The following is a description of a gene set: Human Gene Set: WU_HBX_TARGETS_2_UP studied in species Homo sapiens Genes up-regulated by expression of HBV X protein (HBVgp3) in primary hepatocytes. from publication Wu CG, Salvay DM, Forgues M, Valerie K, Farnsworth J, Markin RS, Wang XW (PMID 11439330) Hepatitis B virus (HBV) is a major risk factor for the development of hepatocellular carcinoma (HCC). HBV encodes the potentially oncogenic HBx protein, which mainly functions as a transcriptional co-activator involving in multiple gene deregulations. However, mechanisms underlying HBx-mediated oncogenicity remain unclear. To determine the role(s) of HBx in the early genesis of HCC, we utilized the NCI Oncochip microarray that contains 2208 human cDNA clones to examine the gene expression profiles in either freshly isolated normal primary adult human hepatocytes (Hhep) or an HCC cell line (SK-Hep-1) ecotopically expressing HBx via an adenoviral system. The gene expression profiles also were determined in liver samples from HBV-infected chronic active hepatitis patients when compared with normal liver samples. The microarray results were validated through Northern blot analysis of the expression of selected genes. Using reciprocally labeling hybridizations, scatterplot analysis of gene expression ratios in human primary hepatocytes expressing HBx demonstrates that microarrays are highly reproducible. The comparison of gene expression profiles between HBx-expressing primary hepatocytes and HBV-infected liver samples shows a consistent alteration of many cellular genes including a subset of oncogenes (such as c-myc and c-myb) and tumor suppressor genes (such as APC, p53, WAF1 and WT1). Furthermore, clustering algorithm analysis showed distinctive gene expression profiles in Hhep and SK-Hep-1 cells. Our findings are consistent with the hypothesis that the deregulation of cellular genes by oncogenic HBx may be an early event that favors hepatocyte proliferation during liver carcinogenesis., and this is the list of marker genes: HSPA1L, PDS5B, ANPEP, MAP2K3, ATP5PF, CSNK1G2, PPP5C, CASP4, BCL2L1, CXCL1, RAB5C, CDKN3, GLRX, UCK2, SLC25A5, YWHAE, CCNG1, FAS, STK25, CDC42BPA, TGFB2, HMGB2, ADGRE3